The following is a description of a gene set: studied in species Homo sapiens Catalysis of the removal of a methyl group from a di or a monomethyl-lysine residue at position 9 of the histone H3 protein. This is a dioxygenase reaction that is dependent on Fe(II) and 2-oxoglutarate. Human Gene Set: GOMF_HISTONE_H3K9ME_H3K9ME2_DEMETHYLASE_ACTIVITY, and this is the list of marker genes: KDM7A, KDM3B, PHF8, HR, KDM3A